Given this list of marker genes DNAL1, DNAH8 (dynein axonemal heavy chain 8), CCDC103, DNAH9, DNAH2, DRC1, DNAH17, NME8, DNAH3, ODAD1, DNAI3, DNAH7 (NCBI Gene Id 56171), DNAH12, DNAI7, CFAP70, DNHD1, DNAI4, DNAH1, CCDC65, DNAH5, DNAI1, DNAI2, here is a description of the gene set: A dynein complex found in eukaryotic cilia and flagella; the motor domain heads interact with adjacent microtubules to generate a sliding force which is converted to a bending motion. Human Gene Set: GOCC_AXONEMAL_DYNEIN_COMPLEX studied in species Homo sapiens